Given this list of marker genes PGM5P4-AS1, KLK6, GPR88, TNFRSF4, PPM1N, FBLN5, ADRA1D, CXCL6, ENSG00000249295, KAZALD1, NKX2-3, SMIM43, ERRFI1-DT, STC2, CCL11, IFIT1, RASL11B, CETP (NCBI Gene Id 1071), TLX1, ANGEL2, here is a description of the gene set: from publication Cao J, O'Day DR, Pliner HA, Kingsley PD, Deng M, Daza RM, Zager MA, Aldinger KA, Blecher-Gonen R, Zhang F, Spielmann M, Palis J, Doherty D, Steemers FJ, Glass IA, Trapnell C, Shendure J (PMID 33184181) Human Gene Set: DESCARTES_MAIN_FETAL_STC2_TLX1_POSITIVE_CELLS The gene expression program underlying the specification of human cell types is of fundamental interest. The study authors generated human cell atlases of gene expression and chromatin accessibility in fetal tissues. For gene expression, the study authors applied three-level combinatorial indexing to >110 samples representing 15 organs, ultimately profiling ~4 million single cells. The study authors leveraged the literature and other atlases to identify and annotate hundreds of cell types and subtypes, both within and across tissues. Our analyses focused on organ-specific specializations of broadly distributed cell types (such as blood, endothelial, and epithelial), sites of fetal erythropoiesis (which notably included the adrenal gland), and integration with mouse developmental atlases (such as conserved specification of blood cells). These data represent a rich resource for the exploration of in vivo human gene expression in diverse tissues and cell types. studied in species Homo sapiens Marker genes curated from the annotated cluster as represented in the Descartes Human Gene Expression During Development database.